The following is a description of a gene set: species: Homo sapiens A small membrane-bounded vesicle that releases its contents by exocytosis in response to insulin stimulation; the contents are enriched in GLUT4, IRAP and VAMP2. Human Gene Set: GOCC_INSULIN_RESPONSIVE_COMPARTMENT, and this is the list of marker genes: SLC2A4, RAB4A, RAB4B, DENND4C, RAB13, MYO5A, RAB10